Given this list of marker genes SLC10A7, SELENOT, DEPDC7, DIPK2A, RNF11, COQ2, SPATA7, MAT2A, MDC1, CYP2R1, GMCL1, TMEM19, MID1IP1, MLKL, SMC3, MADD, RIF1, ATP10D, ARID4A, GEM, CWF19L2, RP2, SPPL2A, MEF2D, TMEM229B, SLC33A1, MARS2, SEPTIN10, FMR1, RNF20, PRPF38B, EPB41L2, PTBP2, TUG1, USP15, DSTYK, CDK19, ZNF398, C6orf62, FBXL4 (F-box and leucine rich repeat protein 4), COPS3, PLCB1, KATNBL1, PHYH, ZWILCH, CCDC88A, ATP13A3, KTI12, PCGF3, PANX1, ZNF706, BIRC3, SLAIN2, RCBTB1 (NCBI Gene Id 55213), PPP1R12A, CHRNB1, U2SURP, RFX7, JMJD1C, CFAP418, CUL3, MCOLN3 (mucolipin TRP cation channel 3), STX4, ZFAND6, GOSR1, SMCHD1, RAD51C, UGDH, DDX42, TRAPPC11, UTRN, TMEM135, GPRASP1, PGR, MAP2K6, MKS1, GEN1, C1GALT1C1, DHX36, KIF13B, TERF2IP, GHITM, STXBP6, SEC23IP, STK4, STX7, CNOT8, SERINC1, HERPUD1, SUCLA2, AIM2, IL31RA, RPF1, NADK2, DOCK8, HERPUD2, MANBA, RETREG1, TIFA, ATF2, IARS1, ATF6, HIF1A, AKAP13, VCPIP1, SBNO1, BCL2, TASP1, DNAJC9, TAOK1, PARG, TBC1D19, SRSF3, AMOT, GABPB2, SDC1, FUCA2, SEC11A, B4GALT4, SLC25A16, NLRP10, C4orf46, NHLRC3, TEX2, EIF4ENIF1, DCTN5, C5orf24 (NCBI Gene Id 134553), TM6SF1, ITPR1, CLSPN, PREX1, DDX23, PPA2, VIRMA, ALG10, SFR1 (SWI5 dependent homologous recombination repair protein 1), ZBTB6, COL19A1, PPP4C, SNAPC3, ARMT1 (acidic residue methyltransferase 1), TYROBP, CSNK1G3, SNX29, ARPC5L, SRSF11, LRRCC1, RBM6, CAPN7, RBM47, ZNF280D, PRKAB2, APAF1, MED21, ATP8B2, CREB1, MAP4, IVNS1ABP, SAMD8, USP12, TASOR2, SLC36A4, NUP160, EIF5B, ORC6, TMEM68, IL17RA, TAF1B, MORF4L1 (mortality factor 4 like 1), DBR1, AZIN1, C1orf159, PELI1, SLC25A51, TXNDC16, PECAM1, CAPZA2, DDX4, USP34, UBE2E1, CCDC158, APCDD1, THOC6, ZCCHC4, ABCA13, METTL25, IL25, VPS26A, SRCAP, RPS6KA5, RNF217, MARF1, CYB5R4, GCNT1, CDS1, SCCPDH (saccharopine dehydrogenase (putative)), XPO1, POLD3, PLCXD2, VWA5A, here is a description of the gene set: studied in species Homo sapiens Genes down-regulated in CD4 T cells: non-Tfh versus Tfh (T follicular helper) from germinal center. from publication Yusuf I, Kageyama R, Monticelli L, Johnston RJ, Ditoro D, Hansen K, Barnett B, Crotty S (PMID 20525889) Human Gene Set: GSE21380_NON_TFH_VS_GERMINAL_CENTER_TFH_CD4_TCELL_DN CD4 T cell help is critical for both the generation and maintenance of germinal centers, and T follicular helper (TFH) cells are the CD4 T cell subset required for this process. SAP (SH2D1A) expression in CD4 T cells is essential for germinal center development. However, SAP-deficient mice have only a moderate defect in TFH differentiation as defined by common TFH surface markers. CXCR5+ TFH cells are found within the germinal center as well as along the boundary regions of T/B cell zones. Here we show that germinal center associated T cells (GC TFH) can be identified by their co-expression of CXCR5 and the GL7 epitope, allowing for phenotypic and functional analysis of TFH and GC TFH populations. Here we show GC TFH are a functionally discrete subset of further polarized TFH cells, with enhanced B cell help capacity and a specialized ability to produce IL-4 in a TH2-independent manner. Strikingly, SAP-deficient mice have an absence of the GC TFH subset and SAP- TFH are defective in IL-4 and IL-21 production. We further demonstrate that SLAM (Slamf1, CD150), a surface receptor that utilizes SAP signaling, is specifically required for IL-4 production by GC TFH. GC TFH cells require IL-4 and IL-21 production for optimal help to B cells. These data illustrate complexities of SAP-dependent SLAM family receptor signaling, revealing a prominent role for SLAM receptor ligation in IL-4 production by germinal center CD4 T cells but not in TFH and GC TFH differentiation.